The following is a description of a gene set: Cluster 3 of genes distinguishing among different B lymphocyte neoplasms. species: Mus musculus Aside from Myc-activating translocations characteristic of plasmacytomas (PCT), little is known about genetic factors and signaling pathways responsible for the development of spontaneous B-cell lineage lymphomas of mice. Here, we characterized the transcriptional profiles of PCT, centroblastic diffuse large B-cell lymphomas (CBL), and high-grade splenic marginal zone B-cell lymphoma (MZL++) using high-throughput quantitative reverse transcription-PCR. Expression profiles of CBL and MZL++ were strikingly similar and quite unlike that of PCT. Among the genes expressed at significantly higher levels by PCT were a number involved in NOTCH signaling, a finding supported by gene set enrichment analyses of microarray data. To investigate the importance of this pathway, NOTCH signaling was blocked in PCT cell lines by treatment with a gamma-secretase inhibitor (GSI) or transduction of a dominant-negative mutant of MAML1. These treatments resulted in reduced expression of NOTCH transcriptional targets in association with impaired proliferation and increased apoptosis. GSI treatment of transformed plasma cells in a primary PCT also induced apoptosis. These results integrate NOTCH activation with oncogenic signaling pathways downstream of translocated Myc in the pathogenesis of mouse PCT, two signaling pathways also implicated in development of human multiple myeloma and T-cell lymphoblastic lymphoma. from publication Shin DM, Shaffer DJ, Wang H, Roopenian DC, Morse HC 3rd (PMID 19010892) Mouse Gene Set: SHIN_B_CELL_LYMPHOMA_CLUSTER_3, and this is the list of marker genes: Nfatc1, Tgfb1, Zeb2, Ltb (lymphotoxin B), Maf, Id2, Lck, Cxcl13, Ccnd1, Nfkb1, Fzd1, Cxcr6, Cd86, Cadm1, Il18, Il2, Irag2, Hhex, Tnfsf13, Ccnd3, Wnt5a, Jak2, Lfng, Nfkb2, Cbx5, Fgr (FGR proto-oncogene, Src family tyrosine kinase), Tnfrsf1a, Bcl2